Given this list of marker genes Arf1, Plcb1 (NCBI Gene Id 98861), Neto1, Cnksr3, Agrn, Grp, Ptpn3, Bpifa5, Fxyd2, Fxyd4, Atp1b2, Fxyd5, Osr1, Chp1, Prss8, Fxyd7, Rangrf, Ank3, Wnk3, Scn4b, Stk39, Nedd4, Fgf13, Nedd4l, Cav3, Slc9a1, Fxyd3, Scn5a, Ywhah, Scn3b, Camk2d, Dmd, Fgf12 (NCBI Gene Id 320320), Bpifa1, Fxyd1, Drd4, Wnk2, Scn2b, Slmap, Wnk1, Atp2b4, Atp1b3, Pcsk9, Tesc, Tescl, Atp1b1, Gpd1l, Commd1, Scn1b, Snta1, Tmem168, Fxyd6, Kcnq1, Nos1, Nherf1, here is a description of the gene set: studied in species Mus musculus Any process that modulates the frequency, rate or extent of sodium ion transmembrane transport. Mouse Gene Set: GOBP_REGULATION_OF_SODIUM_ION_TRANSMEMBRANE_TRANSPORT